The following is a description of a gene set: Signaling by Activin studied in species Homo sapiens Human Gene Set: REACTOME_SIGNALING_BY_ACTIVIN, and this is the list of marker genes: SMAD4, FSTL3, MAPK1, SMAD3, FOXH1, SMAD2, ACVR1B, DRAP1, INHBB, INHBA, INHA, ACVR2A, MAPK3, FST, TGFBR3, ACVR2B (NCBI Gene Id 93), ACVR1C